Given this list of marker genes RAB34, IQCB1, KIAA0753, USP9X, WDR44, here is a description of the gene set: species: Homo sapiens Human Gene Set: GOBP_CYTOSOLIC_CILIOGENESIS The process in which an axoneme is exposed entirely or partially to the cytoplasm or by which the cytoplasmic portion is assembled or extended. Cytosolic ciliogenesis can occur following compartmentalized ciliogenesis, in which the cilium is formed within a compartment separated from the cytoplasm.